Given this list of marker genes RUNX1 (RUNX family transcription factor 1), KRAS, BRD2, RUNX3, HDAC4, EP300, CDKN2A, CBFB, TGFB1, CCND1, here is a description of the gene set: Acetylation of RUNX3 by the histone acetyl transferase p300 (EP300) and the subsequent association of acetylated RUNX3 with BRD2 correlates with upregulation of p14-ARF transcription from the CDKN2A locus. Cyclin D1 (CCND1) negatively regulates RUNX3-facilitated induction of p14-ARF by recruiting histone deacetylase HDAC4 to RUNX3, leading to RUNX3 deacetylation. species: Homo sapiens Reactome Pathway: RUNX3 regulates p14-ARF part of: Transcriptional regulation by RUNX3